The following is a description of a gene set: studied in species Homo sapiens from publication Chen Y, Wang X (PMID 31504780) Genes predicted to be targets of miRBase v22 microRNA hsa-miR-6739-5p in miRDB v6.0 with MirTarget v4 prediction scores > 80 (high confidence targets). Human Gene Set: MIR6739_5P, and this is the list of marker genes: ERBB3, TBX15, ZMYM3, ST3GAL1, NFIA, GLYATL3, CGN, DLC1 (DLC1 Rho GTPase activating protein), ABCC1, AAMP, POU3F4, NPAS3, HAO1, RAVER2, KMT2A, YWHAZ, LIPA, MYCL, CTNNA3, FAM120A, MARK1, RICTOR, KNSTRN, VANGL2, TESK2, HERC3, RPP14, VCL, CDK5, EVC, HLA-DQA1, NALCN, SHISAL1, ATP8B4, PDK3, WDR26, ACSL5, FMO1, PFKFB2 (NCBI Gene Id 5208), C1orf198, PKD2, MAPRE2, TMEFF2, CREBL2, CEP15, ZNF3, GORASP1, AMMECR1, TMEM185B, ANKS1A, ZDHHC9, GPLD1, LYN, MCM10, ADPRHL1, ATP6V1G2, IGF1, RAB5B, ZBTB43, PLCD4, TIGAR, ZDHHC21 (NCBI Gene Id 347748), KLHL3, ZKSCAN7 (NCBI Gene Id 80241), ANKRD17, ADAM23, SPOCK3, BRPF1, SHPRH, RTL5, SLC18A1, MEGF8, MECP2, CCDC30, ABHD13, TIGD3, MAPK8 (mitogen-activated protein kinase 8), BCL9, TOB2, PREX2, SNX27, THSD7A, KCMF1, FILIP1, RGS8, CDCA3, KLHDC10 (NCBI Gene Id 23008), C9orf72, DCAF16, CHD3, ENTPD4, RAB33A, GK5, USP46, KLF8, RIMOC1, TRIM47, RNF175, RBM4B, PTN, SNRK, BTN3A3, TMEM164, UCMA, ACP7, SEMA3G, VTCN1, FNDC3A, APOOL, SAMD10, DSCAM, DNAJC6, TAP2 (transporter 2, ATP binding cassette subfamily B member), FAR2, COLGALT2, BRPF3, YIPF5, TACC1, PSTPIP2, LANCL1 (LanC like glutathione S-transferase 1), IPPK, C6orf89, RABGAP1, FECH, NSD1, CLASP2, PFN2, FOXN1 (forkhead box N1), F5, MCTP1, CLASP1, ARCN1, TTC9, ARFGEF3, GSPT1, ZBTB9, SH3KBP1, PLS3, GOLPH3, TNIK, AGO3, RPH3A, PBX2, YWHAG, RORA, WDR43, ATXN2L, RND3, PIGN, LUZP1 (NCBI Gene Id 7798), PCGF3, SHTN1, HDGFL3, PLA1A, KLF12, NCAN, CXCL12, TRABD2B, ARHGAP36, FBXO4 (NCBI Gene Id 55087), AFF2, LOX, LZTS3, LRRC51, MEX3C, SMIM12, CHTF8, KIF21B, SH3D19, ANTXR1, ASCC3, TGFBR1, ATP1B1, ZNF84, EFNA5, RNASE9, GPRASP3 (G protein-coupled receptor associated sorting protein family member 3), EPM2AIP1, FRA10AC1, GKN2, PPIP5K2, TSC1, RC3H1, PPP1R15B (protein phosphatase 1 regulatory subunit 15B), BLTP3A, GRM5, CXCL14, OSBP, CDH11, PRKAB2, EPN1, ZBTB20, TDRKH, AAK1, XBP1, VPS25, EBF3, RAET1E, ZDHHC18, NOVA2, TMEM217, SULT1C4, EFR3B, GEMIN8, SLC7A14, HLA-DQA2, SENP1, GPC6, TMPRSS13, HSPB6, ASTN1, HSPA9, FGF18, GSTT2B, TMEM127, SLC4A8, MARCHF4, SUOX, CACNA1E, KPNA3, GAS7, HMGN5, SCUBE2, KRBA1, RAD54L2, SRRM4, NOTCH2NLA, ACER2, MARVELD3, NCBP3, FKBP5, STYX, MAT1A, MEP1A, PAPPA, MMD, GUCY1A2, ERGIC1, ATL2 (NCBI Gene Id 64225), PLEKHS1, NEUROD1, EPS8L3, ZEB2, FAXC, PPM1L, CADM1, PARP15, OPN3, NUDC, STRADA, KSR2, RAB8B, CLEC7A, STRN4, LMBRD2, SPICE1, ADNP, TNFAIP1, SLC13A5, ADGRL1, ZNF704, LINC02897, MIA3, FAM234B, GRM6, DPF2, KLF14, TMOD2, TTI2, PCDH12, MBOAT7, ZNF326, WDR5B, RAPGEF6, SELENOI, DGKH, DLG3, TERF1, SNX11